The following is a description of a gene set: species: Homo sapiens from publication Zhong S, Zhang S, Fan X, Wu Q, Yan L, Dong J, Zhang H, Li L, Sun L, Pan N, Xu X, Tang F, Zhang J, Qiao J, Wang X (PMID 29539641) Human Gene Set: ZHONG_PFC_MAJOR_TYPES_NPCS, and this is the list of marker genes: MCM2, GMNN, TUBB4B, CDKN3, CDCA4, GTSE1, DUT, PHGDH, H2AZ2, EFNB1, CDCA5 (cell division cycle associated 5), NUF2, PTTG1, ZWINT, UCP2, PLPP3, TMEM98, PAICS, KIF11, CDCA3 (NCBI Gene Id 83461), PRC1, C19orf48P, MCM4, TUBA1B, ASPM, RPS27L, CKS1B, SGO2, BUB3, KIF22, DHFR, MKI67, IGF2BP1, PBK, HMGB2, SOX9, APOLD1, NUSAP1, KIF23, KIF2C (NCBI Gene Id 11004), CCNA2, TMPO (NCBI Gene Id 7112), DACH1, SGO1, ZFHX4, KNSTRN, GLI3, EMX1, MAD2L1, UHRF1, RPA3, SINHCAF, MDK, H4C3, PLIN2, TACC3, MCM5, CDON, HJURP (Holliday junction recognition protein), CNTLN, NDC80 (NCBI Gene Id 10403), UBE2T, MCM6, RCN1, CCNB2, BUB1, DLGAP5, FEN1, RRM2 (ribonucleotide reductase regulatory subunit M2), MFAP2, DYNC2I2, KIF15, SNRPB, VIM, CKS2, MIS18BP1, TPX2, EMX2, CENPK, ITGB3BP, C21orf58, PAX6, CENPU, PCLAF, CENPW, LDHA, UBE2C, SOX3, RRM1, MCM7, HMGB3, CDC20, PCNA, BTG3, CENPN, HELLS, HAT1, CENPM, PIMREG, CLIC1, TAGLN2, H2AZ1, CCNB1, CENPF, CKAP2L, BIRC5, H2AX, FBXO5, TOP2A, CLSPN, SFRP2, SFRP1, SMC4, NOTCH1, DEPDC1B, EOMES, GNG5, SPC25, GINS2, CDK1, MCM3, SMC2, DTYMK, HSPB1, TGIF1, ID4, CKAP2, CREB5, CDCA7, OTX1, ATAD2, ANP32E, SPAG5, AURKB, ORC6, KPNA2, PRR11, MELK, HES1, OIP5 (Opa interacting protein 5), RNASEH2A, HMGN2